Given this list of marker genes UBA52, AKT3, NRG1, RNF41, USP8, ERBB3, AKT2, ERBB2, NRG2, RPS27A, AKT1 (NCBI Gene Id 207), UBC, UBB, here is a description of the gene set: Reactome Pathway: Downregulation of ERBB2:ERBB3 signaling part of: Downregulation of ERBB2 signaling Level of plasma membrane ERBB3 is regulated by E3 ubiquitin ligase RNF41 (also known as NRDP1), which binds and ubiquitinates both inactive and activated ERBB3, targeting it for degradation. RNF41 is subject to self-ubiquitination which keeps its levels low when ERBB3 is not stimulated, and preserves ERBB3 expression on the cell surface. Self-ubiquitination of RNF41 is reversible, through the action of ubiquitin protease USP8, an enzyme stabilized by AKT-mediated phosphorylation. Therefore, activation of AKT by ERBB2:ERBB3 signaling leads to phosphorylation of USP8, which increases level of RNF41 through deubiquitination, and results in degradation of activated ERBB3 - a negative feedback loop of ERBB3 signaling. Downregulation of EGFR and ERBB4 signaling is explained in pathways Signaling by EGFR and Signaling by ERBB4. species: Homo sapiens